Given this list of marker genes ISCA1, ENSG00000269210, MAP7D3, ZFR, ZNF667, MKKS, PIAS2, CCDC34, CHMP4C, MYO7A, TGFB1I1, SNRNP70, GPRASP3, SMIM15, PABPN1, GP9, TNPO3, GUCY1B1, IPO8, IL11RA, HMCES, ABLIM1, SRY, ARHGAP27, MORF4L1, MYL4, ZBTB14, PMAIP1 (phorbol-12-myristate-13-acetate-induced protein 1), DHRS12, OSBPL1A, CASP2, FAM131A, ZSCAN32, TUBB6, TAFA4, EDEM1, ZNF281, CFAP184, HILPDA, RIMKLB, VWF, GPAT4, MRPL9, OAZ3, HMHB1, ZFHX2, SPOP, GDF3, DBNDD2, RPRD2, NEUROG1, AEBP1 (AE binding protein 1), CUL9, MOS, IFNAR2, PAQR5, WBP1L, HNRNPD, SLC25A51, POU2AF1, DYNC1LI1 (NCBI Gene Id 51143), CCPG1, SLC8A3, MPZL1, VPREB3, COL21A1, CNTROB, COCH, MT2A, ZNF174 (zinc finger protein 174), PPP2CA, CEP78, MAD1L1, ADGRG6, KDM5B, CDK8, HNF4A, TBC1D31, ZNF84, FSTL1 (NCBI Gene Id 65385), SPHK2, TANC2, ZNF560, ZNF582, FAM3A, NRP2, CCDC85A, YBX3, KCNAB3, SLC39A14, N4BP1, NNAT, SLX4IP, HNRNPR, RSKR, DNM3, PLPBP, GSN-AS1, CRHBP, PRR18, PIGZ, THRB, FARP2, ITGAV, CYP26C1, CANT1, TADA2B, BTBD3, TRAPPC1, EXOSC3, SAP30BP, TLR2, TIGD3, PFN2 (NCBI Gene Id 85837), SCG5, BTAF1, RECQL5, KRT81, here is a description of the gene set: Cluster 7 of aberrantly hypermethylated genes in blasts from AML (acute myeloid leukemia) patients. from publication Figueroa ME, Lugthart S, Li Y, Erpelinck-Verschueren C, Deng X, Christos PJ, Schifano E, Booth J, van Putten W, Skrabanek L, Campagne F, Mazumdar M, Greally JM, Valk PJ, Löwenberg B, Delwel R, Melnick A (PMID 20060365) Human Gene Set: FIGUEROA_AML_METHYLATION_CLUSTER_7_UP species: Homo sapiens We hypothesized that DNA methylation distributes into specific patterns in cancer cells, which reflect critical biological differences. We therefore examined the methylation profiles of 344 patients with acute myeloid leukemia (AML). Clustering of these patients by methylation data segregated patients into 16 groups. Five of these groups defined new AML subtypes that shared no other known feature. In addition, DNA methylation profiles segregated patients with CEBPA aberrations from other subtypes of leukemia, defined four epigenetically distinct forms of AML with NPM1 mutations, and showed that established AML1-ETO, CBFb-MYH11, and PML-RARA leukemia entities are associated with specific methylation profiles. We report a 15 gene methylation classifier predictive of overall survival in an independent patient cohort (p < 0.001, adjusted for known covariates).